The following is a description of a gene set: studied in species Homo sapiens Functional anomaly of the kidney persisting for at least three months. Human Gene Set: HP_CHRONIC_KIDNEY_DISEASE Chronic kidney disease, and this is the list of marker genes: STOX1, PPOX, TSC2, APRT, IQCB1, ALG5, CLDN16, CLCNKA, HNF1B, MT-TL1, MT-ATP8, PKD1, MAGI2, FAN1, AGXT, RNU7-1, WDPCP, NUP205, NUP93, GLIS2, ANKFY1, WDR19, NPHP4, BBS1, NDUFAF6, COL4A4, AHI1, PAX2, SAA1, IFNG, COL4A3, TMEM67, PRKCD, NEK8, GON7, SLC4A2, APOA1, ARL6, TMEM126B, EHHADH, IFT172, SOX18, UMOD, CEP19, CEP164, BBS4, COL4A6, CLDN19 (claudin 19), NPHP1, MMP1, NUP133, GSN, BBS12, ANLN, CC2D2A, COQ6, SEC61A1, LAGE3, CORIN, ROBO1, TPRKB, BICC1, LDHA, LYZ, EIF2AK3, MMUT, NUP37, IFT43, CRB2, ZMPSTE24, ACP5, TBC1D8B, PRPS1, SH2B1, PBX1, IFT122, CFHR5, NPHS1, LMX1B, LAMB2, NPHS2, PIGA (NCBI Gene Id 5277), BSND, SCAPER (S-phase cyclin A associated protein in the ER), LZTFL1, ZNF699, CEP290, SCLT1, TRPC6, INVS, MKS1, DZIP1L, GATA3, ALG9, RRM2B, CD2AP, DCDC2, BBS10, CD151, CPT2, SGPL1, TRAF3IP1, TP53RK, JAG1, EMP2, PKHD1, TTC21B, CFAP418, CLCN5, MYO1E, LAMA5, MAFB, FN1, APOL1, DAAM2, PTPRO, RAD51C, SLC41A1 (solute carrier family 41 member 1), CEP83, NPHP3, NUP160, NUP107, PYGM, OSGEP, DSTYK, INF2, SLC2A9, POLRMT, REN, YRDC, MUC1, OCRL, PKDCC, NOS1AP, BBS7, SLC7A7, SARS2, SMARCAL1, NTRK1, ALMS1, ANKS6, PKD2, BNC2, SLC30A9, HNRNPK, NUP85, CHRNA3, COL7A1, BBIP1, COL4A5, MKKS, GAPVD1, WT1, BBS2, DNAJB11, IFT140, SLC34A1 (solute carrier family 34 member 1), GATM, XPNPEP3, FLT1, MYOCD, SLC37A4, CFH, SDCCAG8, SPRY2, BBS9, GCDH, MEFV, IFT27, ACTN4, AVIL, CD81, ALDOB, RPGRIP1L, SLC22A12, CLCNKB, C3, ARHGAP24, KYNU, HBB, IFT56, PUS3, PLCE1, TTC8, TRIM32, ARHGDIA, DGKE, IFT74, CTNS, B2M, BBS5, SRCAP, GANAB, TSC1 (TSC complex subunit 1), COQ8B, MAPKBP1, NOD2 (nucleotide binding oligomerization domain containing 2)